Given this list of marker genes VTN, NINJ1, ITGB7, ACAN, CYTH2, TNR, SMO, ROCK1, IL6, EGR1, here is a description of the gene set: from publication Murakami T, Fujimoto M, Ohtsuki M, Nakagawa H (PMID 11532376) Ultraviolet B irradiation initiates and promotes skin cancers, photo-aging, and immune suppression. In order to elucidate the effect of these processes at the level of gene expression, we used cDNA microarray technology to examine the effect of ultraviolet B irradiation on 588 cancer-related genes in human keratinocytes at 1, 6, and 24 h post-irradiation with a mildly cytotoxic dose of ultraviolet B (170 mJ/cm(2)). The viability of the irradiated keratinocytes was 75% at 24 h post-irradiation. Various cytokeratins and transcription factors were up-regulated within 1 h post-irradiation. After 6 h, expression of a variety of genes related to growth regulation (e.g. p21(WAF1), notch 4, and smoothened), apoptosis (e.g. caspase 10, hTRIP, and CRAF1), DNA repair (ERCC1, XRCC1), cytokines (e.g. IL-6, IL-13, TGF-beta, and endothelin 2), and cell adhesion (e.g. RhoE, and RhoGDI) were altered in human keratinocytes. These data suggest the changes in a cascade of gene expression in human keratinocytes occurring within 24 h after UVB exposure. Although the roles of these cellular genes after UVB-irradiation remain to be elucidated, microarray analysis may provide a new view of gene expression in epidermal keratinocytes following UVB exposure. Human Gene Set: MURAKAMI_UV_RESPONSE_1HR_DN species: Homo sapiens Genes down-regulated in primary keratinocytes at 1 h after UVB irradiation.